The following is a description of a gene set: The absolute number of T cells per volume is above the upper limit of normal. species: Homo sapiens Increased total T cell count Human Gene Set: HP_INCREASED_TOTAL_T_CELL_COUNT, and this is the list of marker genes: HLA-DRB1, BTNL2 (butyrophilin like 2), LYN, IKBKG, MAP3K14, NFKBIA (NFKB inhibitor alpha)